The following is a description of a gene set: The movement of an aminophospholipid molecule from one leaflet of a membrane bilayer to the opposite leaflet. species: Homo sapiens Human Gene Set: GOBP_AMINOPHOSPHOLIPID_TRANSLOCATION, and this is the list of marker genes: ATP8A1, ATP11A, ATP8A2, TMEM30B, ATP8B1, TMEM30A, ATP11C